Given this list of marker genes Cux2, Siae, Gimap4, Eeig1, Ms4a4c, Oxa1l, Lrfn4 (NCBI Gene Id 225875), Arl2, Ly6a, Fgf15, Neu1, Cdk5r1, Fxyd5, Arrb1, Cenpa (centromere protein A), Gad1, Rab6b, Ciita, Fcgrt, Stat4, Cr2, Rabac1, Bglap3, Ms4a6b, Ngef, Pacs1, Bcl2, Pbx3, Rflnb, Rhoh, Jak2, Pou5f1, Apoe, Entpd6, Sell, Pck2, 2410018L13Rik, H2-Aa, Tuba3a, Cmah, Rpa1, Gm11346, Csf1, Zfpm2, here is a description of the gene set: studied in species Mus musculus Genes up-regulated during differentiation of immature to mature B lymphocyte. Mouse Gene Set: HOFFMANN_IMMATURE_TO_MATURE_B_LYMPHOCYTE_UP from publication Hoffmann R, Seidl T, Neeb M, Rolink A, Melchers F (PMID 11779835) Gene expression profiles of five consecutive stages of mouse B cell development were generated with high-density oligonucleotide arrays from as few as 2 x 10(4) ex vivo isolated and flow-cytometrically purified cells. Between 2.8% and 6.8% of all genes change on differentiation from one cellular stage to the next by at least twofold. The entire pathway involves differential expression of 10.7% of all genes. Previously known expression patterns of genes (like surrogate light chain, RAG-1/2, MHC class II, mel-14 antigen) are confirmed. The gene expression patterns of the proliferating pre-BI and large pre-BII cells on the one hand, and the resting immature and mature B cells on the other hand, are most similar to each other. Small pre-BII cells display a pattern that is transitional between these two groups. Most of the genes expressed in early precursors are involved in general processes, like protein folding or cell cycle regulation, whereas more mature precursors express genes involved in more specific molecular programs (cell surface receptors, secreted factors, and adhesion molecules, among others). Between 19 and genes share a given expression pattern. Combining knowledge about gene function and expression pattern allows identification of novel candidate genes potentially involved in self-maintenance of pre-BI cells, allelic exclusion and pre-B cell receptor signaling in large pre BII cells, cell-cycle arrest of small pre-BII cells, propensity toward apoptosis or anergization in immature B cells, propensity toward cell division and activation in mature B cells, and stage-specific interactions with stromal cells in the bone marrow.